Given this list of marker genes DLST, GOT2, PXMP2, AGXT2, AMT, DAO, GCSH, HAO1, DLD, GRHPR, GNMT, KGD4, HOGA1, PRODH2, GLDC (NCBI Gene Id 2731), ALDH4A1 (NCBI Gene Id 8659), AGXT, DDO, OGDH (NCBI Gene Id 4967), here is a description of the gene set: Reactome Pathway: Glyoxylate metabolism and glycine degradation Glyoxylate is generated in the course of glycine and hydroxyproline catabolism and can be converted to oxalate. In humans, this process takes place in the liver. Defects in two enzymes of glyoxylate metabolism, alanine:glyoxylate aminotransferase (AGXT) and glycerate dehydrogenase/glyoxylate reductase (GRHPR), are associated with pathogenic overproduction of oxalate. The reactions that interconvert glycine, glycolate, and glyoxylate and convert glyoxylate to oxalate have been characterized in molecular detail in humans. A reaction sequence for the conversion of hydroxyproline to glyoxylate has been inferred from studies of partially purified extracts of rat and bovine liver but the enzymes involved in the corresponding human reactions have not been identified. species: Homo sapiens part of: Metabolism of amino acids and derivatives